Given this list of marker genes TBX15 (NCBI Gene Id 6913), COL11A1, FGFR2, INPPL1, IFT43, COL11A2, TRIP11, OBSL1, CCDC8, CUL7, CDCA7, ABCC9, PAM16, COL2A1, KAT6B, HSPG2, here is a description of the gene set: Human Gene Set: HP_HYPOPLASTIC_ISCHIA Hypoplastic ischia species: Homo sapiens Underdevelopment of the ischium, which forms the lower and back part of the hip bone.